The following is a description of a gene set: The removal of a ubiquitin-like protein of the NEDD8 type from a protein. species: Mus musculus Mouse Gene Set: GOBP_PROTEIN_DENEDDYLATION, and this is the list of marker genes: Cops7a, Cops2, Cops7b, Cops8, Tor1a, Cops3, Cops6, Cops5, Gps1, Cops4, Senp8